The following is a description of a gene set: part of: Regulation of PD-L1(CD274) Post-translational modification Post-translational modifications (PTMs) of PD-L1 (CD274) play an important regulatory role in modulating immune tolerance in normal physiology. The same mechanism is hijacked by cancer cells to enable immune evasion. PD-L1 protein levels are tightly controlled by multiple mechanisms such as phosphorylation, glycosylation, ubiquitination, etc.. GSK3B is a serine-threonine kinase known to be regulated by multiple growth factor signalling pathways like EGFR, WNT, etc. GSK3B is constitutively active and phosphorylation by upstream pathways inactivates its kinase activity. GSK3B regulates PD-L1 protein stability and glycosylation. GSK3B phosphorylation of PD-L1 at T180 and S184 induces proteasomal degradation of PD-L1 and inhibits its glycosylation. GSK3B-induced phosphorylation facilitates binding of PD-L1 with β-TrCP (BTRC), a substrate recognition subunit of the SCF E3 ubiquitin ligase complex, which promotes PD-L1 ubiquitination and routes it for proteasomal degradation. Moreover, MET phosphorylates GSK3B at tyrosine 56, resulting in GSK3B activation and promotion of PD-L1 degradation (Li etal, 2019). species: Homo sapiens Reactome Pathway: GSK3B-mediated proteasomal degradation of PD-L1(CD274), and this is the list of marker genes: ADRM1, CD274, PSMB2, GSK3B, NEK2, PSMD13, PSMC2, RBX1, PSMC1, PSMB5, PSMB1, COPS5, PSMC5, PSMD14, UBA52, PSMA4, UBC, PSMD6, PSMD8, PSMB4, PSMA3, PSMB3, PSMA7, BTRC, PSMA5, PSMD12, PSMD11, PSMC4, PSMD7, PSMB6, PSMD1, PSMD2 (proteasome 26S subunit ubiquitin receptor, non-ATPase 2), PSMD3, UBB, PSMB7 (NCBI Gene Id 5695), RPS27A, PSMA6, PSMC3, SKP1, PSMA1, SEM1, CUL1, PSMC6, PSMA2